Given this list of marker genes Uba52, Uba52rt, Ubc, Fbxw11, Chuk, Nfkb1 (nuclear factor of kappa light polypeptide gene enhancer in B cells 1, p105), Ubb, Rps27a, Cul1, Ikbkg, Map3k8, Tnip2, Ikbkb (inhibitor of kappaB kinase beta), Skp1, here is a description of the gene set: MAP3K8 (TPL2)-dependent MAPK1/3 activation Mouse Gene Set: REACTOME_MAP3K8_TPL2_DEPENDENT_MAPK1_3_ACTIVATION studied in species Mus musculus